Given this list of marker genes TIMM17A, SST, RAD23A, RAB1A, CALM3, CYRIA, CALM1, ETS2, TPBG, SYN2 (synapsin II), PARM1, PTPRO, VAMP1, CORO1A, MRPS12, UBE2S, PANK3, FKBP1A, E2F4, SFPQ, TPPP, PRKCZ, UROS (uroporphyrinogen III synthase), SMARCA2, EP400 (NCBI Gene Id 84442), CA4, CDK5R1, MEGF8, RGS4, GABRB3, PPP3R1, CHGB, NORAD, TAGLN3, DDX3X, CLTB, ATP2B2, RPS6KA3, HTR2A, HSPA13, MAPK9, PDE4D, MAP2 (NCBI Gene Id 4133), ZNF222, TRIM38, PITPNA, UBE2M, ELAVL2, THY1, GRIN2A (NCBI Gene Id 2903), TGOLN2, CALB2, PCMT1, CAMK2A, RASGRF1, CACNB2, SLC1A1, MAPK1, NECTIN3, KLHDC3, ATP6V1H, NAPA, AZIN1, ENSA, RAB6A, MEF2C, B3GALNT1, PLD3, MAPT, ATXN7L3B, KCNB1, GABRD, DYNC1I1, PPM1E, ATP5F1A, FGF13, FGF12, ATP6V1G2, MAT2A, YWHAE, NRXN1 (neurexin 1), OGT, MAP1B, NUDT21, RNF19B, CDC40, CNTN1, TNFRSF21, CRH, MACIR, MAP2K4, CCKBR, CAP2, NR1D2, TUBA4A, TOP2B, ATP2A2, GNAQ, RANBP9, RAB5A, INPP4A, PLEKHB2, SCN2B, ZBTB18, DNM1L, ACTA1, RAN, GAD1, PITPNB, SRSF10, GRIA1, VDAC1, BRD2 (bromodomain containing 2), UBE2D1, PRKCB, SLC17A7, HSPA8, ILRUN, CALB1, ANK2, HCCS, ATP6V1A, MRPL28, NAPG, DUSP3, NSG1, PRKCG, RBP4, TSPYL2, ATP8A1, KCNJ9, FOXG1, RAP2A, KIF1B, CAMK4, SARS1, CBX5, YWHAZ, FRMPD4, ABI2, CDH22, ITM2B, ITPKA (NCBI Gene Id 3706), GNB5, PIK3CB, PAK1, MBNL2, GFRA2, RAB3A, NUTF2, RBBP4, PENK, MTOR, here is a description of the gene set: from publication Lu T, Pan Y, Kao SY, Li C, Kohane I, Chan J, Yankner BA (PMID 15190254) Human Gene Set: LU_AGING_BRAIN_DN Age down-regulated genes in the human frontal cortex. The ageing of the human brain is a cause of cognitive decline in the elderly and the major risk factor for Alzheimer's disease. The time in life when brain ageing begins is undefined. Here we show that transcriptional profiling of the human frontal cortex from individuals ranging from 26 to 106 years of age defines a set of genes with reduced expression after age 40. These genes play central roles in synaptic plasticity, vesicular transport and mitochondrial function. This is followed by induction of stress response, antioxidant and DNA repair genes. DNA damage is markedly increased in the promoters of genes with reduced expression in the aged cortex. Moreover, these gene promoters are selectively damaged by oxidative stress in cultured human neurons, and show reduced base-excision DNA repair. Thus, DNA damage may reduce the expression of selectively vulnerable genes involved in learning, memory and neuronal survival, initiating a programme of brain ageing that starts early in adult life. species: Homo sapiens